Given this list of marker genes SOS1, ID3, CT62, FAM86C1P, UBR1, TMX4, SMOX, MMAA, TMEM92, CCNY, DDX60L, PHF20, ECD, MAP4K1, ZNF709, C11orf21, EGR1, RBM43, ZNF506, TRMT5, TEX26, HMGB1, BBS9, ADNP, UGT1A6 (UDP glucuronosyltransferase family 1 member A6), LTA4H, REST, OPTC, GIMAP4, LAMP5, ACO2, TEF, N4BP2, NHLRC2, REEP3, CLEC4F, CXCL5, BICD2, MSANTD4, MAP3K3, KL, SNAI3, ZFAND5, B3GLCT, CRCT1, WDSUB1, ZBTB38, ARPC2, JSRP1 (junctional sarcoplasmic reticulum protein 1), DGKQ, CCDC87, PGBD2, RALGPS2, PTPN18, EYA3, TRA2B (NCBI Gene Id 6434), UBE2CP4, ZNF680, SYTL1, MYF6, PTGR2, ING1, MAP2K5, MAGEA4, HSPA13, NID2, TMIGD2, FMOD, PDXDC2P, CAPSL, STX10, RAB3GAP2, DMXL2, DICER1, LINC00320, RAI14, TEKT5, UNK, FANCB, PCDH19, GPX7, CRYM, FIBP, AP5B1, LSM4, ACVR1, UBL7, RNF144A, FN3KRP, ZNF473CR, PRB1, ILF3-DT, DESI2, DNASE2B, INVS, FGF10, GAS1, LINC01015, BUB1B, ZMYM3, HSD17B6, DNAJB8, LRR1, SYNDIG1, NAPG, PHACTR2, ZNF395, CDC42BPG, CD52, ADAT1, PKP1, UPRT, RASA1, DCP1B (NCBI Gene Id 196513), ASB2, PTPN22, PGAP1, MID1, PNKP, ALG9, CDIN1, SERINC3, TRIM25, SLC7A6, S1PR3, DEFB114, ZNF221, TCIRG1, TAS2R19, STARD4, EHD3, RMDN2, RCSD1, OBI1, RASGRF1, ATP2A3, PLSCR1 (NCBI Gene Id 5359), MAGT1, SGSM2, CCNDBP1, ABLIM1, CENPJ, NAALADL2, BEX4, BBS4, ZNRF2, METTL15, ZNF778, RBM8A, MTOR, SCCPDH, STYX, CIMIP2B, PIP4P2, AP4B1, ZNF398, LIX1L, NIFK-AS1, MSMO1, SNX30, ASPM (assembly factor for spindle microtubules), LYRM9, LYG2, ADHFE1, GNAI3, NPVF, CTBS, SNX10, PGM2, GZMA, SYBU, CDC25C, RIC3, GCGR, PBX2, GOLT1B, LAMA1, FAM107B, MIR2052HG, GEN1, APH1B, KRTAP4-12, ARHGEF37, SLC25A24 (NCBI Gene Id 92093), CNOT6, BTBD10, PRPSAP2 (NCBI Gene Id 5636), LZTS2, HSD17B11, PPIP5K2, CD2AP, SMAD3, LIPT1, WASHC4, here is a description of the gene set: Sle2c1 is an NZM2410-derived lupus susceptibility locus that induces an expansion of the B1a cell compartment. B1a cells have a repertoire enriched for autoreactivity, and an expansion of this B cell subset occurs in several mouse models of lupus. Here we showed that expression of Sle2c1 enhances NZB cellular phenotypes that have been associated with autoimmune pathogenesis. A combination of genetic mapping and candidate gene analysis presents Cdkn2c, a gene encoding for cyclin kinase inhibitor p18INK4c (p18), as the top candidate gene for inducing the Slec2c1 associated expansion of B1a cells. A novel SNP in the Cdkn2c promoter is associated with a significantly reduced Cdkn2c expression in the splenic B cells and B1a cells from Sle2c1-carrying mice, which leads to defective G1 cell cycle arrest in splenic B cells and increased proliferation of Pc B1a cells. As cell cycle is differentially regulated in B1a and B2 cells, these results suggest that Cdkn2c play a critical role in B1a cell self renewal, and that its impaired expression leads to an accumulation of these cells with high autoreactive potential. Genes up-regulated in peritoneal cavity B lymphocytes: wildtype versus lupus susceptibility locus Sle2c1. from publication Xu Z, Potula HH, Vallurupalli A, Perry D, Baker H, Croker BP, Dozmorov I, Morel L (PMID 21543644) Human Gene Set: GSE23114_WT_VS_SLE2C1_MOUSE_PERITONEAL_CAVITY_B1A_BCELL_UP species: Homo sapiens